The following is a description of a gene set: studied in species Mus musculus Mouse Gene Set: GOMF_INOSITOL_HEXAKISPHOSPHATE_BINDING Binding to inositol hexakisphosphate., and this is the list of marker genes: Itpr3, Gle1, Snap91, Mtor, Xpr1